Given this list of marker genes LTC4S, PCK1, CIDEC, OR2H2, GBP2, SERPINA3, ACOX1 (NCBI Gene Id 8308), COL15A1, HLA-B, HIPK3, IFNGR1, HP, TAP2, STAT1, CP, ABCA1, here is a description of the gene set: Troglitazone (TGZ), a member of the thiazolidinedione class of anti-diabetic compounds and a peroxisome proliferator activator receptor-gamma (PPAR-gamma) agonist, restores systemic insulin sensitivity and improves the full insulin resistance syndrome in vivo. The mechanisms underlying its in vivo function are not understood. Here we investigated the potential functional interaction between PPAR-gamma and NF-kappaB in adipocytes. We show that TGZ selectively blocked tumor necrosis factor-alpha-induced and NF-kappaB-dependent repression of multiple adipocyte-specific genes and induction of growth phase and other genes. This occurs without interfering with NF-kappaB expression, activation, nuclear translocation, or DNA binding and without suppressing NF-kappaB-dependent survival signals. Notably, the expressions of some tumor necrosis factor-alpha-induced genes in adipocytes were unaffected by PPAR-gamma activation. In reporter gene assays in HeLa cells, ectopic expression of PPAR-gamma abolished induction of a NF-kappaB-responsive reporter gene by the p65 subunit (RelA) of NF-kappaB, and the inhibition was further enhanced in the presence of TGZ. Conversely, overexpression of p65 inhibited induction of a PPAR-gamma-responsive reporter gene by activated PPAR-gamma in a dose-dependent manner. The inhibitory effect was independent of the presence of NF-kappaB-binding sites in the promoter region. Other NF-kappaB family members, p50 and c-Rel as well as the S276A mutant of p65, blocked PPAR-gamma-mediated gene transcription less effectively. Thus, p65 antagonizes the transcriptional regulatory activity of PPAR-gamma in adipocytes, and PPAR-gamma activation can at least partially override the inhibitory effects of p65 on the expression of key adipocyte genes. Our data suggest that inhibition of NF-kappaB activity is a mechanism by which PPAR-gamma agonists improve insulin sensitivity in vivo and that adipocyte NF-kappaB is a potential therapeutic target for obesity-linked type 2 diabetes. Adipocyte abundant genes up-regulated in 3T3-L1 cells (fibroblasts induced to differentiate to adipocytes) in response to troglitazone and TNF. from publication Ruan H, Pownall HJ, Lodish HF (PMID 12732648) studied in species Mus musculus Human Gene Set: RUAN_RESPONSE_TO_TNF_TROGLITAZONE_UP